The following is a description of a gene set: species: Mus musculus from publication Yevshin I, Sharipov R, Kolmykov S, Kondrakhin Y, Kolpakov F (PMID 30445619) Mouse Gene Set: PDX1_TARGET_GENES Genes containing one or more binding sites for (Pdx1) in their promoter regions (TSS -1000,+100 bp) as identified by GTRD version 20.06 ChIP-seq harmonization., and this is the list of marker genes: Kctd6, Cfap97, Osbp, Gm14570, Tshz1, Gm12637, Cald1, Pkn2, 4930555F03Rik, Or4a2, Galnt3, Ctdspl, Gm6077, Gm24679, Trp53i13, Cpa2, Tmem260, Crebl2, Otud4, 2900022M07Rik, Mir1945, Mir5099, Mef2c, Tmem11, Fbxo46 (F-box protein 46), Clec2e, Zfp408, Zbtb18, Npepps, Pou2f3, Gspt1, Atp6ap2, Rora, Akr1c13, Matr3, St14, Gm5254, Cdk2ap2, Skida1, Sik3, Gm12987, Dnpep, Creb3l1, Usp43, Zfp945, Sp3 (NCBI Gene Id 320543), Herc1, Dhx16, Cdnf, Rnd2, Srm, Xxylt1, Zfp473, Frg2f1, Fzd5, Cox6c, Ncoa6, Mecom, Fam135a, Gm14174, Ttc32, Gm22656, Msh5, Stk3 (NCBI Gene Id 80435), Mrps33, Gpkow, Gripap1, Lrrc7, Pdzrn4, Hoxaas2, Rhd, Adgrb3, Ints6 (integrator complex subunit 6), mt-Tr, Gm10637, Pigk, Hip1, Gtpbp1, Hnrnph1, Rbm25, Il18, Gm25173, Abi2, Gm6644, Gm16023, Gm25420, Myt1l, Gm15564, Mep1a, Spcs3, Vmp1, mt-Nd4l, Gm5210, Rny3, Mir3085, Ankhd1, Poc1a, Rcor3, Tmem163, Vezf1 (NCBI Gene Id 263341), Hnrnpk, Ppm1l, C130089K02Rik, Vapb, Acbd5, Uts2b, Gm23528, Cyp4b1-ps1, Saa2, Tex14, Csgalnact2, Rfx6, Gm12502, Map3k8, Lrrfip1, Rps11-ps3, Prdm13, 4933424M12Rik, Wnt3, Mir6236, Gm3235, Otx1, Nhlh2, Luc7l3, Nalf1, Rabggtb, Setd2 (NCBI Gene Id 70927), Hnrnph3, Frg1, Myt1, Sidt1, Polg, Fry, Acvr1b, Kctd5 (NCBI Gene Id 69259), Foxp2, Grhl2, Tcim, Gm5099, Akr1e1 (aldo-keto reductase family 1, member E1), Tesk2, Gm17800, Dcun1d3, Dop1a, Supt7l, Gm23034, Hdac9, Ing3, Mir7-2, D8Ertd738e, Sgms1os1 (NCBI Gene Id 67188), Klhl1, Ppm1h (NCBI Gene Id 78540), Zc3h7a, Or8h8, Zbtb20, Gm16336, Anapc15, Gm23225, Zfp964, Aknad1, Rapgef2, Phc2, Or4m1, Gm11585, Gata4, A930012L18Rik, Arhgap1, Meg3, Dap, Rab11a, Slc15a2, Gm11690, Smad7, Lrwd1, Lmo4, Gm22965, Bclaf3, Rpl36-ps12, Ccdc88a, 2210016L21Rik (NCBI Gene Id 72357), Zfp949, Slc2a5, Lrrc42, Gm19590, Gm15464, Gm10248, Pkia, Tcp1, Gm35409, Zmpste24, Col11a2, Tlnrd1, Egr2, Dmbt1 (NCBI Gene Id 270001), Etv1, Smarcd2, Trp73, Baz1a, Cmip, Anxa10, 4930449E01Rik, Wbp2nl, Gm4791, Lrrc8d, Gm28441, 4930455H04Rik, Luc7l2, Tanc1, Gnas, Tnfaip3, Trim17, Rimklb, Scpppq1, Ankfn1, Rasa1, Tph2, Otop3, Or5al6, Rad21l, Cpeb3, Morc4, Tnk1, Gpx3, Rbfox2, Arid1b (AT-rich interaction domain 1B), Gm22379, Cep170, Dcaf11, Tcf12, Snx6, Alkbh5, Zfhx4, 1810053B23Rik, Smkr-ps, Car11, Ap1m1, Gm8675, H6pd, Polr3b, Ankrd22, C79798, Ccdc77, Pou2af2, Ttc3, Unc93b1, Pex7 (NCBI Gene Id 18634), Calcrl, Syt16, B4galt3, Rab40c, Zfp667, Nfe2l1, H2bc26, Lmo3, Psmc4, Gck, Gm15681, Ogg1, Gm6899, Gm16223, Meis2, 0610040J01Rik, Dixdc1, Fstl5, Gm12100, 1700028E10Rik, Gzmk, D830032E09Rik, Brca2, Ighv5-8, Hhex, Pafah1b1, Zfp672, Nt5c3, Tcf4, A530020G20Rik, Abcd2, Gm17546 (NCBI Gene Id 102634389), mt-Nd4, Nkx2-5, Zfp652, Tcf24, Spred2, 1700008O03Rik, Anapc5, Bcas1, Dennd11, B3glct, Fa2h, Rac1, Tafa1, Iapp, Wdr75, Rgma, Zc3h12d, Pkd2, Nnmt, Cyp4b1, Serpini2, 9630013D21Rik, Uba1, Ruvbl1, Sgms1, Fmc1, Chd7, Tnfsf12 (NCBI Gene Id 21944), Adam23, Mir802, Mir466q, Gm13690, Tcerg1, Gm15441, Ighg2b, Khdc4, Svopl, Taf5, 4933408N05Rik, Gm22163, 2900052L18Rik, Gm16344, Gbf1, Crlf2 (NCBI Gene Id 57914), Chuk, Gm5493, 1700049E17Rik2, Bcas3os2, Gm15322, Dusp6, Akr1c12, Tbx3os2, Fsd1l, Mir1906-1, Gm11228, Lgr6 (NCBI Gene Id 329252), Tmem97, 6820431F20Rik, G6pc2, Slc37a1, Spc25, Tspan5, Tm6sf1, Esrra, Gab3, Ppargc1a, Depp1, Chaf1a, Zfp512b, Rcan3, Arhgap11a, Tsacc, Myl6, Arhgef10l, Ip6k2, Fbxl22, Gm12508, F8, Zfp236, Asl, Gm12258, H2ac25 (NCBI Gene Id 319162), Pnpla8 (NCBI Gene Id 67452), Dctpp1, 1810007C17Rik, 1500015A07Rik, Mtfr2, Gm16876, Cop1, Xlr3c, Fyn, Tnfsfm13, Cdk11b, Gm3329, Yipf5, Prorp, Slc25a12, Slc31a1, C130083M11Rik, Vrk3, Cela1, Cct3, Ccdc162, Crem (cAMP responsive element modulator), Brpf1, Setd4, Sptlc2, Mrps22, Zfp207, Kcnh2, Phactr1, Gabarapl2 (NCBI Gene Id 93739), Celf1, mt-Cytb, Exoc1, Def8, Phyhipl, Rab25, Fam110b, Fam133b, Ndel1, Msantd7, Akr1c19, Unc13b, Bhmt1b, Prkab2, Myo10 (myosin X), Madd, Gm16364, Nsmaf, Slc4a1ap, Pax6, Has2os, Fam78a, Map3k5, Gm22603 (NCBI Gene Id 115485830), Rpl18a, Ccdc30, Ss18l2, Alyref2, C9orf72, A730061H03Rik, Hexd, Chn1, Flywch2, Cct5, Gm25896, Gm26871, Mdh1, Rps18-ps4, Ift80 (NCBI Gene Id 68259), Gm16253, Cyp4f18, Ccdc32, Vrk2 (NCBI Gene Id 69922), Xlr3b, Slc6a20a, Kdm5b, Ncoa2